The following is a description of a gene set: Human Gene Set: AIZARANI_LIVER_C10_MVECS_1 from publication Aizarani N, Saviano A, Sagar, Mailly L, Durand S, Herman JS, Pessaux P, Baumert TF, Grün D (PMID 31292543) studied in species Homo sapiens, and this is the list of marker genes: HS3ST1, TNS2, GNG11, IFITM3, IFI27, CPNE2, ACP5, CDH5, MYO1C, PDGFB, ACVRL1, UACA, ID1 (inhibitor of DNA binding 1), ADAM15, KLF2, WARS1, ADAMTS9, EFNB2, MYADM, BMPR2, ACKR1, YBX3, NFIB, F2R, SPTBN1, PDLIM1, NPDC1, FAM107A, RNASE1, ITGA6, CSRNP1, HDAC7, PCDH12, ASAP1, HEG1, NTS, IL6ST, MEIS2, SLCO2A1, RDX (NCBI Gene Id 5962), CYYR1, JUNB, NOSTRIN, GASK1B, ARHGAP31, CD36, GSN, EPHB4, ADAMTS1, MGP, FXYD6, ARHGAP23, TSPAN7, FLT1, CD9, RGCC, ARAP3, GARRE1, TUBA1A, EMP2, LDB2, LRRC32, RAMP3, EDN1, RAMP2, PTPRB, PECAM1, CLEC14A, VWA1, DOCK9, HLA-DRB5, ERG, SOCS3 (NCBI Gene Id 9021), ROBO4, TEK, PLPP3, CHSY1, TCF4, LIMS2, CALCRL, RBMS3, PLVAP, COL4A1, NUAK1, KDR, SRPX, ITM2A, CAVIN2, DYSF, CPE, C11orf96, EGFL7, WWTR1, EMP1, TMTC1, PEA15, FOSB, ESAM, CD93, CD320, ADCY4, FILIP1, TM4SF18, APP, NOTCH4, CDC42EP4 (NCBI Gene Id 91740), SOX18, HLA-E, A2M, PCDH17, ITPRIP, PCAT19, GNA11, EFNB1, ALPL, BTNL9, CCN2, NFIA, ENG, EPAS1, TSPAN18, PTPN14, ID3, NDRG1, NR2F2, ANXA2, PGM5, TGM2 (transglutaminase 2), LAMB2, SH2D3C, IL33, SASH1, TACC1, PTPRM, CRIM1, CAV2, HECW2, MMRN2, KLF7, SERPINB6, FOXC1, CDKN1A, RIPOR1, GALNT15, JAM2, PDE2A, PRSS23, TIMP2, SEC14L1, PRCP, EMCN, PIK3R3, TAGLN2, CLEC3B, RBP7, TMCC3, CCL15-CCL14, COL15A1, NOS3, TGFBR2, ATP13A3, XIST, CD59, IGFBP4, PLAT, ADGRL4, KCNN3, PLPP1, CD34, EDNRB, SGK1, SHANK3, DPYSL3, F8, KLF4, GNAS, RPS6KA2, ITGA5, TINAGL1, LMO2, PTGDS, SOX17, TNS1, FBLN2, LMNA, CCM2L, ST6GALNAC3, GJA1, SMAD6, GIMAP8, TGFBR3, LIFR, STOM, CAVIN1, SNRK, PTPRG, ECE1, MCC, SPRY1, VIM (vimentin), BHLHE40, C7, SHROOM4 (shroom family member 4), DNASE1L3, FLNB, HYAL2, THBD, RUNX1T1, MIDN, BCAM, AIF1L, DLC1, RPGR, SOX7, GRB10, RHOJ, CXCL12, FKBP1A, TIE1, TMEM204, GAS6, SPARC, NES, LIMCH1, MYCT1, MMRN1, MAST4, NRN1, CD300LG, SYNPO, SHE, CAV1, CLIC4, ADGRF5, KLF9, NEDD9, VWF, ARL15, SNTB2, TM4SF1, DUSP6, APOLD1, INPP1, CRIP2, ATN1, PALMD, ELK3, TSC22D1, CASKIN2, IGFBP7, ARHGAP29, NPR1, TPM4, AQP1, TP53I11, HES1, CHRM3, EXOC3L2, TIMP3, CDC42EP3 (NCBI Gene Id 10602), INSR, TUBB6, SPARCL1, NHERF2, S1PR1 (sphingosine-1-phosphate receptor 1), PALM, CNTNAP3B, CLDN5, FZD4